The following is a description of a gene set: Human Gene Set: GOBP_POSITIVE_REGULATION_OF_SMALL_MOLECULE_METABOLIC_PROCESS Any process that activates or increases the frequency, rate or extent of a small molecule metabolic process. studied in species Homo sapiens, and this is the list of marker genes: HIF1A, APOE, PLA2G3, PRKN, PARK7, AKT2, SRC, MLST8, IRS2 (insulin receptor substrate 2), AVPR1A, CPT1A, ACTN3, DYRK2, ARNT, LDLRAP1, GAPDHS, WDR5, PSEN1, PRKACA, PLIN5, SREBF2, WNT4, PPP1CA, MTOR, ELOVL5, PRKAA1, PRKAA2 (NCBI Gene Id 5563), MIR107, ENO1, TAFAZZIN, CD244 (CD244 molecule), MAP2K1, CLYBL, NNMT, KLHL25, IL1B, PINK1, SIRT1, STAR, P2RY1, APOC2, PPP1R3E, SORBS1, QKI, LPGAT1, P2RX7, VCP, HTR2A, KAT2B, NTSR1, PPARA, FGF1, BMP6, ZBTB20, PPTC7, INS, CD74, ABCD1 (NCBI Gene Id 215), PPP4R3A, TWIST1, PHKA1, APOA1, GUCA1A, PTGS2, MIR182, ARPP19, DAB2, GPLD1, KPNB1, NDUFC2, IFNG, PRKAG1, INSR, FOXO1, KAT2A, HMGB1, ADCYAP1R1, AVP, GNAI1, PPARG, SREBF1, EPM2AIP1 (EPM2A interacting protein 1), GPIHBP1 (NCBI Gene Id 338328), TREM2, GHSR, PPP1R3G, RPTOR, PPARD, PTH, CRY1, CYP7A1, AGTR1, MLXIPL, PTPN2, MLYCD, MIR96, IGF2, GPER1, PMAIP1, APOA4, SLC4A4, TIGAR, MIR210, ABCG1, NR1H2, NR1H3 (NCBI Gene Id 113429), GCK, BEND3, STAT3, MID1IP1, DDB1 (damage specific DNA binding protein 1), PPARGC1A, NR1D1, MTLN, NR1H4, CES1, SIRT7, GUCA1ANB-GUCA1A, AKT1, IGF1, APOA5, SLC45A3, TMSB4X, MBTPS2, TNF, AVPR1B, PID1, P2RY6, STARD4, ABCD2, SNCA, PAQR3, ADIPOQ, DGAT2, GPD1, RDH10, APP, ADCY10, GCG, PPP1R3B (protein phosphatase 1 regulatory subunit 3B), PRKAG2, AGT, IL4, ABCG4, LHCGR, PRXL2C, SIRT2, UCHL1, SCAP, PRKAG3, PHKG2, PTH1R, PPP4R3B, PLAA, GDF15, ADM, MAPK1, MIR103A1, IRS1